Given this list of marker genes RC3H1, CARD9, ARID5A, LOXL3, IL12B, IL12RB1, CD69, MIR21, ZC3H12A, MALT1, BRD2, STAT5A, TNFSF18, NLRP10, CLEC7A, TYK2, PRKCQ (NCBI Gene Id 5588), EPHB2, JAK3, IL23A, ZBTB7B, OPA1, SMAD7, RC3H2, JUNB, EP300, LGALS1, BATF, TBX21, FOXP3, NFKBID, NFKBIZ, IL27RA, IL2, IL23R, CLEC6A, ASCL2, BRD4, JAK2, here is a description of the gene set: Human Gene Set: GOBP_REGULATION_OF_T_HELPER_17_TYPE_IMMUNE_RESPONSE Any process that modulates the frequency, rate or extent of T-helper 17 type immune response. studied in species Homo sapiens